The following is a description of a gene set: Human Gene Set: GSE43955_1H_VS_20H_ACT_CD4_TCELL_WITH_TGFB_IL6_DN Genes down-regulated in CD4 T helper cells Th17 treated with TGFB1 and IL6: 1h versus 20h. from publication Yosef N, Shalek AK, Gaublomme JT, Jin H, Lee Y, Awasthi A, Wu C, Karwacz K, Xiao S, Jorgolli M, Gennert D, Satija R, Shakya A, Lu DY, Trombetta JJ, Pillai MR, Ratcliffe PJ, Coleman ML, Bix M, Tantin D, Park H, Kuchroo VK, Regev A (PMID 23467089) Despite their enormous importance, the molecular circuits that control the differentiation of Th17 cells remain largely unknown. Recent studies have reconstructed regulatory networks in mammalian cells, but have focused on short-term responses and relied on perturbation approaches that cannot be applied to primary T cells. Here, we develop a systematic strategy – combining transcriptional profiling at high temporal resolution, novel computational algorithms, and innovative nanowire-based tools for performing gene perturbations in primary T cells – to derive and experimentally validate a temporal model of the dynamic regulatory network that controls Th17 differentiation. The network is arranged into two self-reinforcing and mutually antagonistic modules that either suppress or promote Th17 differentiation. The two modules contain 12 novel regulators with no previous implication in Th17 differentiation, which may be essential to maintain the appropriate balance of Th17 and other CD4+ T cell subsets. Overall, our study identifies and validates 39 regulatory factors that are embedded within a comprehensive temporal network and identifies novel drug targets and organizational principles for the differentiation of Th17 cells. species: Homo sapiens, and this is the list of marker genes: RNF19B, PCSK2, PLIN2, FRRS1, NEDD4L, COL10A1, PLAC8, HEPH, MX1, ADAM28, HTR1F, ACTR3, TRAF3, ACP5, DHRS7, SLC51A, FCRLA, HK2, HS3ST1, MET, CDK14, CXCL9, CTSS, PRDM1, WRN, FOLR2, AOC3, S100A6, FLNB, DDX3Y, NRP1, PPARG, EPB41L4B, AGAP1, CLPTM1L, PTGS2, NEDD1, CASP4, CISH, PCDHA10, KDELR3, CDKN1C, TSR1, DCN, CCR7 (C-C motif chemokine receptor 7), IGFBP1, CPNE3, MARK1, GABRR1, TWIST1, PDRG1, ANAPC15, ECM1, UGDH, CFB, CYTIP, CHRNB2 (cholinergic receptor nicotinic beta 2 subunit), GPC4, GLRX, B2M (beta-2-microglobulin), BIRC3, KIF1C, GPR37, PLAC9, CACNA2D1, ORM1, SCOC, IFNAR1, EPHA4, NNMT, UIMC1, PLS3, FBN1, CD59, GNAI2, RAD51, ZFR, ADORA2B, ACRV1, IRF7, DNTT, AZIN1, HOXA4, CD8A, LPL, FHL1, FIP1L1, RHD, EPHA6, SIT1, VCL, PTPRR (NCBI Gene Id 5801), PPP1R3C, MGP, FERMT2, ZNF638, SARAF, DDR2, CEP131, IRF8, SLC30A4, PHLDA1, CSF2RB, NUPR1, APOC1, SNAI2, SRY, ABCA2, COL5A2, APOC2 (NCBI Gene Id 344), FEM1A, TAGLN, DERL2, TIMP3, KCNS2, LY86, HIC1, C5orf15, TAF9, B4GALT6, RPL14 (ribosomal protein L14), SGIP1, PTTG1, NFKBIZ, NAV1, IL1A, ABCD3, DDIT3, ELL2, SNHG6, CSF3, SEMA3C, MYH7, CETN1, RPGR, KLF12, LY6E, IKZF2, TUBB, FZD9, ISG20, PDE1A, OSMR, NCK2, OLR1, GTF3C1, MDFI (NCBI Gene Id 4188), NDN, TNC, COL1A2, CTSE, ITM2B, WWTR1, IL10, SCAMP1, CTSK, TNPO3, CNN3, ATXN2, SERPINB2, TMEM176B, CD5L (CD5 molecule like), CYSTM1, SIM1, C3AR1, PAM, GNA13, MX2 (NCBI Gene Id 4600), SERPINE2, CCT6A (NCBI Gene Id 908), MYO10, FRMD6, SIAE, PGLYRP1, CLIC4, NEDD4, OSBPL5, AGFG1, TFDP1 (NCBI Gene Id 7027), KLHL7, COPA, HNF4A, HOXB9, C19orf12, CSF1, SASH1, UQCC5, KCNH1, APBB2, HGSNAT, FGFR1, CR2, CDKN2A, AEBP1, GJA1, NR2F1 (nuclear receptor subfamily 2 group F member 1), NSMF, BASP1, WDR1, TGDS